The following is a description of a gene set: species: Mus musculus Mouse Gene Set: GOMF_ANNEALING_ACTIVITY An activity that facilitates the formation of a complementary double-stranded polynucleotide molecule., and this is the list of marker genes: Eif4h (NCBI Gene Id 52314), Ddx3x, Rad54l, Eif4b, Smarcal1, Fxr1, Hnrnpa1, Anxa1, D1Pas1, Zranb3, Trp53, Smarca1, Recql, Fmr1